The following is a description of a gene set: An anomaly of the inner mucous membrane of the uterus. studied in species Homo sapiens Human Gene Set: HP_ABNORMAL_ENDOMETRIUM_MORPHOLOGY Abnormal endometrium morphology, and this is the list of marker genes: SEC23B, HPS6, AKT1, KRAS, PMS1, SDHB, SDHD, EPCAM, POLE, POLD1, THOC6, MSH2, BMPR1A, MSH3, KLLN, TGFBR2, PTEN, SDHC (succinate dehydrogenase complex subunit C), NTHL1, MLH3, MSH6, SLC6A17, MLH1, CDH1, PMS2, PIK3CA, GREM1, USF3